The following is a description of a gene set: The directed movement of a protein to a specific location in the endoplasmic reticulum. species: Mus musculus Mouse Gene Set: GOBP_ESTABLISHMENT_OF_PROTEIN_LOCALIZATION_TO_ENDOPLASMIC_RETICULUM, and this is the list of marker genes: Srp72, Tram1, Srprb (signal recognition particle receptor, B subunit), Spcs3, Get3, Man1a, Srpra, Srp54b, Zfand2a, Srp14, Spcs1, Rab3gap2, Ubl4a, Sgtb, Edem1, Sec62, Macf1, Hspa5, Vps54, Srp19, Zfand2b, Folr1, Sec61g, Arxes2, Sec61b, Glp1r, Ryr2, Tram1l1, Get1, Sec61a1, Get4, Rab10, Srp54c, Srp68, Arxes1, Sgta, Srp54a, Sec63, Tram2, Srp9, Spcs2, Rab3gap1, Bag6 (NCBI Gene Id 80605), Herpud1, Chmp4b, Folr2, Ssr3, Sec61a2